The following is a description of a gene set: Human Gene Set: HP_GENERALIZED_OSTEOPOROSIS Generalized osteoporosis species: Homo sapiens, and this is the list of marker genes: COL1A2, LMNA, SATB2, TRPV4, COL1A1, ZBTB20, MMP14, SP7, GNPTAB, CDC73, CHST3, TENT5A, CBS, B3GAT3, MEN1, COL2A1, CCN6, STAT1, GCM2